The following is a description of a gene set: part of: Miro GTPase Cycle This event has been computationally inferred from an event that has been demonstrated in another species.<p>The inference is based on the homology mapping from PANTHER. Briefly, reactions for which all involved PhysicalEntities (in input, output and catalyst) have a mapped orthologue/paralogue (for complexes at least 75% of components must have a mapping) are inferred to the other species. electronically inferred by orthology from the curated human pathway species: Mus musculus Reactome Pathway: RHOT1 GTPase cycle, and this is the list of marker genes: Myo19, Trak1